Given this list of marker genes Gpx4, Alox12b, Gpx1, Gpx2, Aloxe3, Alox15, Alox12, here is a description of the gene set: electronically inferred by orthology from the curated human pathway This event has been computationally inferred from an event that has been demonstrated in another species.<p>The inference is based on the homology mapping from PANTHER. Briefly, reactions for which all involved PhysicalEntities (in input, output and catalyst) have a mapped orthologue/paralogue (for complexes at least 75% of components must have a mapping) are inferred to the other species. Reactome Pathway: Synthesis of 12-eicosatetraenoic acid derivatives part of: Arachidonate metabolism species: Mus musculus